The following is a description of a gene set: species: Homo sapiens Human Gene Set: GOCC_ESCRT_I_COMPLEX An endosomal sorting complex required for transport. It consists of the class E vacuolar protein sorting (Vps) proteins and interacts with ubiquitinated cargoes., and this is the list of marker genes: VPS37D, UBAP1, TSG101, VPS37C, MVB12A, VPS28, DIAPH3, UEVLD, VPS37A, VPS37B, UBAP1L, MVB12B